The following is a description of a gene set: Maternal effect genes, based on mouse models wih female fertility defects. Human Gene Set: MATZUK_MATERNAL_EFFECT from publication Matzuk MM, Lamb DJ (PMID 18989307) Reproduction is required for the survival of all mammalian species, and thousands of essential 'sex' genes are conserved through evolution. Basic research helps to define these genes and the mechanisms responsible for the development, function and regulation of the male and female reproductive systems. However, many infertile couples continue to be labeled with the diagnosis of idiopathic infertility or given descriptive diagnoses that do not provide a cause for their defect. For other individuals with a known etiology, effective cures are lacking, although their infertility is often bypassed with assisted reproductive technologies (ART), some accompanied by safety or ethical concerns. Certainly, progress in the field of reproduction has been realized in the twenty-first century with advances in the understanding of the regulation of fertility, with the production of over 400 mutant mouse models with a reproductive phenotype and with the promise of regenerative gonadal stem cells. Indeed, the past six years have witnessed a virtual explosion in the identification of gene mutations or polymorphisms that cause or are linked to human infertility. Translation of these findings to the clinic remains slow, however, as do new methods to diagnose and treat infertile couples. Additionally, new approaches to contraception remain elusive. Nevertheless, the basic and clinical advances in the understanding of the molecular controls of reproduction are impressive and will ultimately improve patient care. studied in species Homo sapiens, and this is the list of marker genes: DPPA3, NPM2, HSF1, CSF2, ZFP36L2, ZAR1, UBE2A, DNMT3L, NLRP5